The following is a description of a gene set: species: Homo sapiens Any process that modulates the rate or extent of heart growth. Heart growth is the increase in size or mass of the heart. Human Gene Set: GOBP_REGULATION_OF_HEART_GROWTH, and this is the list of marker genes: MIR25, MIR509-1, PROX1, CTDP1, TGFBR3, HEY2, MIR17HG, G6PD, MIR199A1 (NCBI Gene Id 406976), FGFR2, DUSP6, TGFBR1, MIR222, BASP1, PPARA (NCBI Gene Id 84730), ERBB4, MAPK14, CAV3, FGF9, TBX5, PIM1, MEF2C, MIR199B, MIR208A, RUNX1, ZFPM2 (zinc finger protein, FOG family member 2), YAP1, BMP10 (NCBI Gene Id 27302), NOG, RGS2, MIR590, COL14A1, EDN1, RBPJ, RBP4, GATA6, TBX2, JARID2, YY1, CDK1, MIR200B, MIR548C, MIR19A, NOTCH1, VGLL4, MIR873, MYH6, GLI1 (NCBI Gene Id 2735), ACACB, MIR204, FGFR1, PAK1, FGF20, RGS4, NKX2-5, MIR19B1, WT1, FGF2, NRG1, GSK3A, FOXP1, WNT2, TBX20, PI16, KCNK2, SAV1, IGF1, CCNB1, MAPK11, BMPR1A (NCBI Gene Id 8035), MIR1-1, TP73, PARP2, TOMM70, AKAP6